The following is a description of a gene set: Human Gene Set: KONG_E2F1_TARGETS Functions encoded by single genes in lower organisms are often represented by multiple related genes in the mammalian genome. An example is the retinoblastoma and E2F families of proteins that regulate transcription during the cell cycle. Analysis of gene function using germline mutations is often confounded by overlapping function resulting in compensation. Indeed, in cells deleted of the E2F1 or E2F3 genes, there is an increase in the expression of the other family member. To avoid complications of compensatory effects, we have used small-interfering RNAs that target individual E2F proteins to generate a temporary loss of E2F function. We find that both E2F1 and E2F3 are required for cells to enter the S phase from a quiescent state, whereas only E2F3 is necessary for the S phase in growing cells. We also find that the acute loss of E2F3 activity affects the expression of genes encoding DNA replication and mitotic activities, whereas loss of E2F1 affects a limited number of genes that are distinct from those regulated by E2F3. We conclude that the long-term loss of E2F activity does lead to compensation by other family members and that the analysis of acute loss of function reveals specific and distinct roles for these proteins. from publication Kong LJ, Chang JT, Bild AH, Nevins JR (PMID 16909124) studied in species Mus musculus Genes up-regulated in MEF cells (embryonic fibroblast) at 16 h after serum stimulation and knockdown of E2F1 by RNAi., and this is the list of marker genes: H2AX, E2F1, CFL2, NUSAP1, PRG4 (proteoglycan 4), ANKRD1, KPNA1, GAS5, NUP58, HMGA2, CCL20